Given this list of marker genes Itpr1, Nr3c1, Fbn2, Ssh2, Dnm2, Szrd1, Efemp2, Plekhm3, Atp2b1, Ap1s3, Birc6, Cox5a, Ptprd, Prrx1, Camk1, Npas3, Dpy19l4, Pabpc6, Elf2, Dhh, Spop, Spta1, Hcn1, Rere, Ebf2, Zfp11, Dmtf1, Pex5l, Vgll3, Coro1c, G2e3, Poli, Shc1 (src homology 2 domain-containing transforming protein C1), Nrarp, Mmp13, Fam149a, Dpf1, Ski, Rgs12, Larp4b, Epha4, Siae, Adamts5, Zfp629, Fras1, Chn2, Hycc1, Pdp1, Xrn1, Fry, Tox3, Nanos1, Zfp36l1, Bcas1, Spryd7, Glis3, Pid1, Lhfpl6, Ncoa7, Zbtb7c, Igf2r, Khdrbs1, Esrrg, Iigp1, Plxna2, Trp53inp1, Rnf170, Lsm5, Sf3b1, Zfp423 (zinc finger protein 423), Sgip1, Ociad2, Zfp521, Nrg3, Amot, Wee1, Farp1, Lamp1, Ogdh, Ap3m1, Lhfpl4, Dpp10, Nrbf2, Nfatc3, Zfhx4, Snx13, Crtac1, Hoxc8, Mapre2, Rell1, Fnip1, Uba6, Nkx6-3, Ranbp6, Smim13, Tsr1, Pde12, Alcam, Pgpep1l, Grk4, Ap1s2, Dync2i1, Ntrk2, Nova1, Slc16a6, Sox11, Ypel2, Gxylt2, Ezr, Mrps33, Onecut2, Ssrp1, Ccnt2, Ephb6, Gcnt2, Fhip1b, Tgfbrap1, Creb5, Naa15, Fbxw7, Trim36, Atf6 (activating transcription factor 6), Dnaaf9, Slc39a11, Dennd1b, Napg, A630023A22Rik, Smc2, P2rx7, Ssr3, Hnrnpa2b1, Atf2, Ankrd13a, Dtwd1, Lnpep, Jarid2, Ccdc120, Esr1, Zfp282, Lrrn4cl, Slc16a4, Dera, Eef1e1, Cd74, Cpne8 (NCBI Gene Id 70271), Lrp2, Ago1, Plcb1, Nuak1, Pum2 (pumilio RNA-binding family member 2), Mmab, Gcnt1, Pusl1, Sos1, Lgals3, Sec24d, Brd3, Ttyh1, Rreb1 (NCBI Gene Id 68750), Pde1c, Vax2, Pcdh12, Frs2, Trim12c, Tmc2, Epha5, Epdr1, Dlg1, Hook3, Rims2, Rbm41, Mmgt1, 2310002L09Rik, Creb1, Wdr46, Insc, Acer2, Slc49a4, Ism1, Tgfbr2, Tnfaip8, Nin, Abraxas2, Epha7, Pfkfb2, Tmem263, Alpl, Hyal4, Synj2, Sirt1, Arap2 (ArfGAP with RhoGAP domain, ankyrin repeat and PH domain 2), Samd5, Acsl4, Ap2a2 (adaptor-related protein complex 2, alpha 2 subunit), Ccdc117, Nbea, Sash1, Spred1, Rragc, Evc2, Foxc1, Crat, Efnb3, Cd2ap, Hapln1, Pdcd10, Slc43a1, Arx, Dcun1d3, Pts, Crkl, Rhobtb3, Ankfy1, Angpt1, Cyp2j12, Dyrk1a, Chp1, Elavl3, Rnf122 (NCBI Gene Id 68867), Lrrc8d, Mcoln1 (mucolipin 1), Zranb3, Dnajc14, Myo10, Ppargc1a, Nbr1, Inpp4a, Zbed6, Mmrn1, Apol11b, Mbnl1, Arid3b, Tomm70a, Aoah, Gpm6a, Hapstr1, Ccdc68, Mlxip, Mapk4, Gpatch11, Dnajc13, Arl8b, Arhgap11a, Has2, H2-M2, Micu3, Abcb10, Slc38a9, Lin7a, Dvl3, Eif5, Lypd6b, Rhot1, Clmp, Rictor, Tfap2a, Rps6ka5 (ribosomal protein S6 kinase, polypeptide 5), Nr3c2, Stk17b, Rtkn2 (rhotekin 2), Rnf138, Tppp, Gba1, Ucp1, Tent5a, Zcchc24, Cdh4, Tanc2, Zfhx3, Tet1, Tcf12, Rab22a, Mgat3, Tmem164, Grm1, St7, Pcgf3, Tnrc6b, Kmt5a, Slc39a9, Ppm1k, Gpbp1l1, Dppa2, here is a description of the gene set: studied in species Mus musculus from publication Chen Y, Wang X (PMID 31504780) Genes predicted to be targets of miRBase v22 microRNA mmu_miR_211_5p in miRDB v6.0 with MirTarget v4 prediction scores > 80 (high confidence targets). Mouse Gene Set: MIR_211_5P